The following is a description of a gene set: Human Gene Set: GOBP_NEGATIVE_REGULATION_OF_SKELETAL_MUSCLE_CELL_DIFFERENTIATION species: Homo sapiens Any process that stops, prevents or reduces the frequency, rate or extent of skeletal muscle cell differentiation., and this is the list of marker genes: SIRT2, MYOCD, EPHB1, SIX4, MSTN, AKIRIN1, S100B